Given this list of marker genes Casp1, Scn7a, Pycard, Trpv3, Trpv4, Oxsr1, Atp1a1, Wnk3, Nlrp3, here is a description of the gene set: Mouse Gene Set: GOBP_OSMOSENSORY_SIGNALING_PATHWAY The series of molecular signals initiated in response to osmotic change. species: Mus musculus